Given this list of marker genes AGFG1, PML, PDGFRA, SERPINF2, PNKD, UBA52, OTUD1, ABHD17B, HTR2B, ARID2, PRDM4, MEP1A, DACH1, MXI1, SRPK2, LRRTM3, SYTL4 (synaptotagmin like 4, NCBI Gene Id 94121), APC, MYZAP, ARMC8, NUFIP2, SPSB4, NEO1, NCAM1, SHC4, YBEY, DGKH, SNAP25, SOCS6, IPMK, BMP7, GNG2, BTBD3, CHIC1, MR1, JMJD4, TENM2, SPN, ZCCHC14, JAGN1, CERS6, SOWAHC (sosondowah ankyrin repeat domain family member C), BAG4, here is a description of the gene set: studied in species Homo sapiens Human Gene Set: MIR1298_5P from publication Chen Y, Wang X (PMID 31504780) Genes predicted to be targets of miRBase v22 microRNA hsa-miR-1298-5p in miRDB v6.0 with MirTarget v4 prediction scores > 80 (high confidence targets).